Given this list of marker genes Hagh, Hoga1, Aldh2, Adh5, Glo1, Adh4, Gatd1, Aldh3b1, Akr1a1, Agxt2, Agxt, Esd, Haghl, Pnkd, Park7, Pdxp, here is a description of the gene set: Mouse Gene Set: GOBP_ALDEHYDE_CATABOLIC_PROCESS species: Mus musculus The chemical reactions and pathways resulting in the breakdown of aldehydes, any organic compound with the formula R-CH=O.